The following is a description of a gene set: species: Homo sapiens Human Gene Set: WP_MICROGLIA_PATHOGEN_PHAGOCYTOSIS_PATHWAY Microglia pathogen phagocytosis pathway, and this is the list of marker genes: VAV1, ITGB2 (integrin subunit beta 2), NCF1, SYK, PIK3C2A, CYBA, TREM1, VAV3, PIK3CA, LAT, RAC3, C1QC, PLCG2 (phospholipase C gamma 2), RAC2, CYBB, FCER1G, NCF2, PIK3R2, ARPC1B, C1QB, PIK3C3, PIK3R6, ITGAM, TREM2, NCKAP1L, PTPN6, C1QA, VAV2, FCGR1A (Fc gamma receptor Ia), TYROBP, NCF4, LYN, PIK3R3, PIK3R1, PIK3CD, PIK3CG, PIK3CB, SIGLEC7, HCK, RAC1